Given this list of marker genes Grin2a, Trpc7, Cldn17, Kcnq4, Gabrp, Atp6-ps, Kcnd2, Grid1, Kcns3, Cacnb1, Trpc5, Atp5f1d, Hcn3, Kcne4, Kcna1, Ttyh1, Dmac2l, Amigo1, Pkd1l1, Kcng2, Ostm1, Gabra1, Glra1, Cacna1d, mt-Atp6, Kcnv2, Scn10a, Slc17a8 (solute carrier family 17 (sodium-dependent inorganic phosphate cotransporter), member 8), Gabrg2, Cacng2, Catsperd, Hspa2, Hcn1, Dpp10, Gabrq, Cngb1, Trpm5, Cldn4, Pkd1, Pex5l, Trpc3, Glra3, Kcna3, Abcb8, Scn1a, Scn4b, Chrnb4, mt-Atp8, Kcnc3, Kcnj13, Tmem37, Kcng3, Kcnh5, Dpp6, Scn2a, Kcnip3 (Kv channel interacting protein 3, calsenilin), Stx1a, Kcna10, Grin1 (glutamate receptor, ionotropic, NMDA1 (zeta 1)), Hcn4, Scnn1b, Cnga1, Kcne1 (potassium voltage-gated channel, Isk-related subfamily, member 1), Cacna1c, Kcnj10, Ryr2, Pacc1, Catsperg2, Gabrr1, Kcnd3, Gabra5, Cacna1b, Smdt1, Kcnh1, Shisa9, Chrna1, Porcn, Clic5, Cacna1i, Vamp2, Clic4, Scn4a, Kcna4, Grin2d, Gabrg3, Tmem109, Gabrb3, Kcnma1, Cybb (NCBI Gene Id 97621), Kcnq3, Atp5me, Cnih2, Cacna2d3, Kcnk4, Pde4d, Chrna3, Clcnka, Kcnj12, Lrrc55, Kcnh8, Atp5mf, Cachd1, Fkbp1b, Ano1, Clcc1, Micu3, Ttyh3, Kcnj8, Clic1, Kcnj5, Grid2, Shisa6, Snap25, Atp5mc2, Trpc6, Kcnmb3, Chrna7, Clic6, Kcnj3, Ano2, Atp5mj, Trpc1, Scnn1g, Chrna9, Pkd2, Atp5pb, Kcnk2, Catspere1, Lrrc8e, Grin3a, Micu1, Kcnu1, Ttyh2, Clcn2, Lrrc8d, Kcnd1, Abcc8, Glra2, Kcnc2, Ryr1, Gabra2, Vwc2, Kcnb1, Gria1 (glutamate receptor, ionotropic, AMPA1 (alpha 1)), Scnn1a, Sumo1, Shisa8, Kcnab2, Tpcn2, Kcnip2, Ano6, Trpc2, Chrnd, Chrnb3, Atp5f1e, Cacna2d2, Vwc2l, Trpv5, Calm2, Best2, Kcnj14, Tpcn1, Chrng, Kcna2, Htr3b, Kcng1, Atp5f1c, Cftr, Kcnk1, Kcnip1, Olfm2, Clcnkb, Trpc4, Cacna1s, Gabrb2, Catsperb, Clic3, Gria2, Nalcn, Lrrc8b, Kcnq1, Cacnb2, Atp5pf, Scn2b, Atp5mc3, Hvcn1, Pkd2l1, Cacna1g, Atp5mg, Abhd6, Hcn2, Olfm3, Scn8a, Mfsd8, Eps8, Gpr89, Grik4, Catsper4, Gria4, Glrb, Mcu (mitochondrial calcium uniporter), Kcnmb1, Scn3a, Kcnf1, Gabrb1, Kcnmb4, Grik3, Gabrr2, Chrnb1, Slco6c1, Scn1b, Gabra6, Best3, Ptk2b, Scn11a, Atg5lrt, Sestd1, Grin3b, Kcnv1, Kcng4, Kcnc1, Chrne, Cnih3, Akap6, Abcc9, Kcnj9, Kcnj4, Calm1, Kcnh2, Kcnh7, Scn5a, Cacna1a, Kcnj1, Catspere2, Trpv6, Calm3, Kcnk7, Ptpa, Stac3, Kcne3, Sacm1l, Lrrc26, Slc26a6, Chrnb2, Chrna2, Lrrtm4, Glra4, Grik5 (NCBI Gene Id 14809), Gabra3, Catsperz, Dlg3, Kcnj16, Pkd1l3, Kcna7, Ccdc51, Kcnj6, Slc5a3, Chrna6, Gabrg1, Clcn1, Kcnj11, Dlg2, Kcnb2, Kcnh3, Catsperg1, Cntnap2, Grin2c, Kcne5 (potassium voltage-gated channel subfamily E regulatory subunit 5), Ryr3 (NCBI Gene Id 99099), Kcns1, Atp5mc1 (ATP synthase membrane subunit c locus 1), Cacnb4, Cnga3, Cacna1f, Chrna4, Lrrc8a, Catsper3, Trpm4, Abhd12, Unc80, Atp5f1a, Cnga2, Best1, Stxbp5, Catsper1, Atp5mk, Chrna5, Cacng8, Kcna5, Scn3b, Cacng3, Cacna2d1, Nrn1, Cttn, Cacna1e, Cacng1, Trdn, Lrg1, Kcnq2 (NCBI Gene Id 16536), Kcna6, Scn9a, Cacna1h, Kcnq5, Htr3a, Kcnj2, Cacng4, Cngb3, Clcn7, Fkbp1a, Cacng7, Tmem249, Tmem262, Cacnb3, Grik1, Grik2, Slc17a6, Kcnab1, Kcnk13, Kcnmb2, Catsper2, Kcnab3, Kcns2, Cacng5, Grin2b, Efcab9, Kcnip4, Slc17a7, Lrrc52, Lrrc38, Lrrc8c, Atp5po, Cnga4, Akap9, Mcub, Atp5f1b, Cpt1c, Micu2, Kcnj15, Cacng6, Gabrd, Gria3, Kcne2 (NCBI Gene Id 69143), Olfm1, Atp5pd, Dlg4, C2cd6, Cacna2d4, Kcnc4, Shisa7, Gabra4, here is a description of the gene set: species: Mus musculus A protein complex that spans a membrane and forms a water-filled channel across the phospholipid bilayer allowing selective monoatomic ion transport down its electrochemical gradient. Mouse Gene Set: GOCC_MONOATOMIC_ION_CHANNEL_COMPLEX